The following is a description of a gene set: Human Gene Set: GSE37416_0H_VS_24H_F_TULARENSIS_LVS_NEUTROPHIL_DN Genes down-regulated in comparison of control polymorphonuclear leukocytes (PMN) at 0 h versus PMN treated with F. tularensis vaccine at 24 h. from publication Schwartz JT, Bandyopadhyay S, Kobayashi SD, McCracken J, Whitney AR, Deleo FR, Allen LA (PMID 22986450) We demonstrated recently that both constitutive and FAS-triggered apoptosis of human neutrophils are profoundly impaired by Francisella tularensis, but how this is achieved is largely unknown. To test the hypothesis that changes in neutrophil gene expression contribute to this phenotype, we used human oligonucleotide microarrays to identify differentially regulated genes in cells infected with F. tularensis strain LVS compared with uninfected controls. In order to examine the effect of F. tularensis on the neutrophil transcriptome, we performed microarray expression analysis on human neutrophils treated with F. tularensis subsp. holarctica live vaccine strain (LVS). species: Homo sapiens, and this is the list of marker genes: SPAG9, REL, XRCC2, HPCAL1, ZHX2, ADIPOR2, PHF23, UBE2V2 (ubiquitin conjugating enzyme E2 V2), HSD17B4, KANSL3, SLC31A1, CEP95, HAPLN2, ABCF1 (NCBI Gene Id 23), RALGAPA1, CDK2, GPAT4, QKI, AKAP10, ATP6V1D, SEC22B, FTH1, UQCRC2, LIF, ATP6V1F, HOOK3, KCNK5, ZNF395, LINC00847, PDK1, DIABLO, VDAC2, RREB1, G3BP2, SIGLEC15, NFKBIE, ARL5B, CCDC93, NFKBIB, ATP6V1C1, TNFRSF1B, PLD6, PLEKHB2, TBC1D2, PRXL2B, TAF9B, FNDC3A, P4HB, PLEKHA2, TMA16, CNOT2, DDHD1, DDX41, STX4, RASSF5, INSIG1, DHX40, VNN3P, PTGES, ARHGAP18, P2RX4, CIDEC, HDHD5, B3GNT5, PPME1, FKBP15, ITCH, TXNDC11, SGF29, SERP1, CRY1, GTPBP2, ZNF267, GALNT9, CFAP36, MEA1 (male-enhanced antigen 1), UBAP2, LZTS2, MTFP1, SLC43A3 (NCBI Gene Id 55543), BZW1, CHMP4B, TFDP1, CBFA2T2, CCDC107, CRTC2, CCNG2, EIF4EBP1, C16orf87, ZNF665, MAPK1IP1L, CHD9, SLC25A16, ZBTB1, ZMIZ1, NSMCE2, PDE4D (NCBI Gene Id 654081), GALC, ERO1A, OLR1, SETD5, ZNF292, CYFIP2, ZC3H12A, SLC25A26, GPBP1, ACP6 (acid phosphatase 6, lysophosphatidic), NR4A1, TM9SF3, BRAF, GPAA1, TGM3, HCAR3, HPS5, C7orf50, CISD2, WBP11, CREB3, SGSH, MLLT6, ZNF277, SH3BP5, PIK3C2B, ARHGDIA (NCBI Gene Id 396), KDM5B, IER3, MRGBP, LSM12, GUK1, FAM50A, ATG12, EDEM1, DLG5, FBXL13, ASCC1, RBPJ, RBKS, DGKA, ITGA7, RYBP, LAMB3, MAPK6, WDR45B, GBA3, ZNF12, FUT11, CAPN7, MFAP1 (microfibril associated protein 1), FBXO34, USP28, UPF3B, MAFG, CLDND1, INTS13, HCST, TIMM8A, SNN, NPC1, C5orf15, TFG, MFSD14A, PLAGL2, ANAPC16, LINC00343, VEGFB, PDCD4, RUNX3, UBXN4, CTNNAL1, GADD45G, CXCL2, STAT4, TNFAIP3, TBC1D22A, SNHG12, DYNC2I1, GNA15, GRINA, GGTLC1, TRAF3, RAB8B, SAV1, CFDP1 (craniofacial development protein 1), SLC15A4, TNFAIP8, DERL1, GADD45B, BABAM2, ALKBH5, ADAMTS20, MCOLN1, ELL2, SULF2, MALT1, NUP58, SLC2A3, ICAM1, NGLY1, KMT2E (NCBI Gene Id 84147)